Given this list of marker genes Tom1l2, Smo, Ptch1, Msh6, Snai1, Mlh1, here is a description of the gene set: studied in species Mus musculus Mouse Gene Set: MP_INCREASED_BASAL_CELL_CARCINOMA_INCIDENCE from publication Motenko H, Neuhauser SB, O'Keefe M, Richardson JE (PMID 26092688) Mouse genes annotated to increased basal cell carcinoma incidence (MP:0004208) retrieved from the Mouse Genome Informatics database via MouseMine